The following is a description of a gene set: Human Gene Set: WEBER_METHYLATED_HCP_IN_SPERM_UP from publication Weber M, Hellmann I, Stadler MB, Ramos L, Pääbo S, Rebhan M, Schübeler D (PMID 17334365) To gain insight into the function of DNA methylation at cis-regulatory regions and its impact on gene expression, we measured methylation, RNA polymerase occupancy and histone modifications at 16,000 promoters in primary human somatic and germline cells. We find CpG-poor promoters hypermethylated in somatic cells, which does not preclude their activity. This methylation is present in male gametes and results in evolutionary loss of CpG dinucleotides, as measured by divergence between humans and primates. In contrast, strong CpG island promoters are mostly unmethylated, even when inactive. Weak CpG island promoters are distinct, as they are preferential targets for de novo methylation in somatic cells. Notably, most germline-specific genes are methylated in somatic cells, suggesting additional functional selection. These results show that promoter sequence and gene function are major predictors of promoter methylation states. Moreover, we observe that inactive unmethylated CpG island promoters show elevated levels of dimethylation of Lys4 of histone H3, suggesting that this chromatin mark may protect DNA from methylation. studied in species Homo sapiens Methylated germline-specific genes with high-CpG-density promoters (HCP) in sperm., and this is the list of marker genes: TCP11, DKKL1, PHF7, FTMT, SPATA22, HSPB9, REC8, LPIN1, GAPDHS, TRPM4, TPTE, BOLL, MOV10L1, DAZL, PLAAT5, POTEG, PRSS50, SPACA1, ODF2, CATSPER2